The following is a description of a gene set: species: Homo sapiens Any of the smallest contractile units of a myofibril (striated muscle fiber). Human Gene Set: GOCC_MYOFILAMENT, and this is the list of marker genes: MYBPC3, TNNI1, TPM4, MYOM1, ACTA1, TPM1, TMOD3, TMOD2, TRIM32, TNNC1, TPM2, TNNC2, TPM3, TMOD1, LMOD3 (leiomodin 3), MYBPHL, TTN, TNNT1, LMOD1 (leiomodin 1), TMOD4, TNNT3, TNNT2, PVALEF, LMOD2, TNNI2, TNNI3